The following is a description of a gene set: A highly compacted molecule of DNA and associated proteins resulting in a cytologically distinct structure. Human Gene Set: GOCC_CONDENSED_CHROMOSOME species: Homo sapiens, and this is the list of marker genes: RPA1, ITGB3BP, RGS12, BRD4, CEBPB, CDT1, SMARCA5, SPDL1, PLK1, PHF6, CHMP7, CHMP4B, FAM9C, FANCD2, DCTN5, BRCA1, RNF212B, ZNF276, NUP133, PAFAH1B1, H3-4, DYNLT3, KMT5B, BUB1, SGO1, CENPN (NCBI Gene Id 55839), FBXO28, CENPL, CDX2, ZW10, CENPH, HORMAD1, APC, PINX1, KIF18A, SMARCC2, GTF2B, SMC4, SEPTIN7, NCAPH2, SGO2, H2AX, CENPS, SUN2, NUP85, CKAP5, CENPO, PSMC3IP, XRCC4, SMC6, PHF10, BUB3, H3-3A, INCENP, CENPU, CHMP5, MTBP, DYNC1LI2, REC8, PPP1CC, TUBA1A, FAM9B, DCTN3, NUP160, DNMT3L, L3MBTL1, NSMCE3, RAD1, TP53BP1, CDC20, HJURP, RIF1, CHMP6, SEH1L, NUP37, TEX12, SEC13 (NCBI Gene Id 6396), CHMP1A, SMARCB1, MIS12, BUB1B, AURKA, ESRRB, PPP1R12A, CHMP4C, ACTB, STAG3, ATRX, ARID2, KIF22, RAD21, HNRNPU, LRPPRC, KASH5 (KASH domain containing 5), KIF2C, FKBP6, SLF1, EID3, RAD9A, SEPTIN6, MEAF6, CENPQ, SYCE3, ADD3, CLASP1, NCAPH, PBRM1, ACTL6A, ACTL6B, SPAG5, CBX5, HSF1, CENPE, CHMP4BP1, PLK2 (NCBI Gene Id 10769), DSN1, TRAPPC12, SKA3, HMGB1, PSEN2, P3H4, FAM9A, KNTC1, CENPC, AKAP8, TTK, SUV39H1, SPC25, BOD1L2, CBX3, AHCTF1 (AT-hook containing transcription factor 1), NCAPD3, CENPA, GPATCH11, SMARCE1, HUS1, SEPTIN2, SMC5, CENPX, PMF1, SKA1, CENPV, SMARCA4, PLK5, KMT5C, ERCC6L, HUS1B, CCNB1IP1, CHMP2A, SYCE2, TEX14, CHEK1, SLF2, RCC1, NDEL1, DYNLL1, NEK2, RSPH1, BRD7, SS18L1, RAD9B, TOPBP1, CHAMP1, NUP107, NDE1 (NCBI Gene Id 95348), MEI4, SMC3, RAD51, NCAPG, BLM, CENPB, MTCL1, AURKC, CHMP1B, TPR, CENPF, DCTN1, AGO3, ORC2, XPO1, RNF212, SUGT1, ANAPC16, FBXW11 (NCBI Gene Id 23291), SMARCD2, CENPI, DCTN4, ZWINT, MEIKIN, SYCE1L, KIFAP3, CLIP1, CDK2, CTCF, CFDP1, RANGAP1, CLASP2, KIF2B, SETMAR, DYNC1I1, NUP43, PLK3, HMGB2 (NCBI Gene Id 3148), SYCE1, DYNC1LI1, SMARCD1, DCTN2, TTN, TOP3B, MLH3, MAD2L1, PHF2, ZWILCH, KNSTRN, IHO1, NSMCE2, NSMCE1, NIFK, SHOC1, MAD1L1, MACROH2A1, FIRRM, SMC1A, BIRC5, CHMP4A, SMC2, TUBG1, MSH4, BRCA2, HORMAD2, DMC1, BANF1, KAT2B, CENPM (NCBI Gene Id 79019), CENPP, SYCP3, RAD50, SUMO3, UBE2I, NCAPD2, RRS1 (ribosome biogenesis regulator 1 homolog), NUP98, RASSF2, NUF2, HSPA2, NSMCE4A, NOL6, CSNK1A1, DCTN6, LRWD1, KANSL1, LIG4, KAT5, SPOUT1, SMC1B, SPC24, MKI67, SYCP1, KAT8, SKA2, ZNF207, SMARCC1, CENPK, NUDCD2, TEX11, SYCP2, BAZ1B, PSEN1, NCAPG2, BANF2, C14orf39, CENPW, AURKB, KNL1, SYCP2L, MLH1 (mutL homolog 1), CENPT, SYN1 (synapsin I), SIN3A, NDC80, TOP2A, CHMP3, NSL1, PRP4K, CCNB1, BOD1, H3-3B, CHMP2B